The following is a description of a gene set: species: Homo sapiens The aggregation, arrangement and bonding together of a set of components to form a plasma membrane raft. Human Gene Set: GOBP_PLASMA_MEMBRANE_RAFT_ASSEMBLY, and this is the list of marker genes: IQGAP1, ILK (integrin linked kinase), CAV3 (caveolin 3), FLOT1, CAV1, EMP2, COL6A1, PACSIN2, MIR138-1, CAV2